Given this list of marker genes Eif4ebp1, Dixdc1, Pja2, Tmem255a, Baz2a, Hnrnpk, Lbr, Il17rd, Ankrd10, Trib2, Kdm7a (NCBI Gene Id 338523), Ttc23l, Ankrd17, Brinp2, Ppp4r3a, Arfgap3, Sar1a (NCBI Gene Id 67913), Elapor2, Krt26, Klhl24, Tmeff1, Enpp4, Ipmk (NCBI Gene Id 69718), Dyrk1a, 1700018B08Rik, Melk, Prr3, Setd1b (SET domain containing 1B), Agtr1b, Neurl1a, Klhl7, Kcnh8, Dera, Immt, Pcbp2, Sp4, Gask1a, Eea1, Ptgs2, Papss2, Vxn, Lrrc39, Rbpms, Ppp3r1, Arid2, Phf2, Uhrf2, Dner, Lemd3, Taf3, Hmgxb4, St3gal3, Alkbh7, Fam3c (NCBI Gene Id 27999), Ptprm, Mapkapk3, Eif5b, Brwd1, Ncoa1, Cnnm4, Zmynd8, Lmo4, Tbcel, Hnrnpc, Prss3b, Clk2, Nid2, Mdh1, Pdk1, Rbfox1, Ascl1, Mmgt1, Chd2, Cd163, Dll1, Tbc1d32, Zfp119b, Snx2, Sh3bgrl2, Tnfaip8l3 (NCBI Gene Id 244882), Zfp703, Fbxo11, Usp49, Cacna1g, Ddx3x, Kcnf1, Trpc5, Dnaja2, Mtdh, Chrna5, Nabp1, Slc30a8, Ermn, Pdzrn4, Znrf3, Wee2, Chic1, Ect2, Hycc2, Tcf24, Igfbp5, Cyp3a25, Eif4h, Tfcp2, Calcr, Lrba, Tmed5, Cntln, Tjp1, U2surp, Enc1, Luzp2, Zfta, Ccdc116, Appl1, Gm14295, Rtf1, Tm2d1, Lrp2bp, Prdx3, Nemp2, Adcyap1, Ulk1, Mfsd6, Ints6 (NCBI Gene Id 73038), Tmem167, Or2v1, Fam13c, Zbtb43, Slitrk1, Cacnb4, Smyd4, Nuak2 (NUAK family, SNF1-like kinase, 2), Nexmif, Mrc1, Ogt, Acsl4, Ces2e, Bicd1, Hdac1, Tmem200a, Rlim, Camk4, Dmc1, Cpne8, Vcan, Wapl, Satb2, Tnrc6b, Noc3l, Epha7, Rock1, Scoc, Ttc39b, Strip2, Crot, Ntf3, Bcar3, Usp21, Dlx1, Schip1, Zc3hav1l, Arhgef38, Hal, Kif26a, Cdk19, Selenot, Psd3, Tlcd4 (TLC domain containing 4), Spry4, Fars2, Elovl6, Gclc, Foxo1, Hoxd9, Ric1, Nsfl1c (NCBI Gene Id 386649), Bpnt2, Tcf7l2, Khdrbs3, Btrc, Sec23a, Sema5a, Ypel2, Zfp462, Rnf6 (ring finger protein (C3H2C3 type) 6), Klrb1b, Rbm12b1, Cdk2, Arl14epl, Usp10, Heatr3, Tab2, Klhl2, Zbtb6, Enpp1, Ei24 (NCBI Gene Id 13663), Tmem106b, Ppfia2, Ctbp1, Meis1, Fndc9 (fibronectin type III domain containing 9), Prelid3b, Btg1, Fem1c, Nadk, Scnn1g, Adamtsl1, Ttc39c, Sos1, Sh3kbp1 (SH3-domain kinase binding protein 1), Iqschfp, Abce1, Pcdh19, Nr0b1, Pdgfra, Ing3, Zdhhc3, Hoxa5, Gulp1, E2f5, Bicd2, Reep3, Ptx3, Celf1, Anks1b, Nfxl1, Morc3, Kcnd3, Focad, Nfib, Kif1b, Zfp871, Gfral, Snap25, Med26, Cebpg, Samd4, Frmd3, Zfp948, Spry2, Six4, Gm6377, Npy2r, Zfp950, Eml4, Tle3, Stim2, Mark2, Akr1b1, Arrdc3, Fnip2, Zfp442, Zfp607a, Tnfrsf19, Tsc22d2, Krt222, Ccdc65, Stk26, Armcx1 (armadillo repeat containing, X-linked 1), Zfp36l1, Gusb, Chn2, Dscam (DS cell adhesion molecule), Rab12 (RAB12, member RAS oncogene family), Metap1, Zzz3 (NCBI Gene Id 99926), Crebzf, Ttc9, Ctbp2, Sp9, Cetn1, Dppa4, Scai, Tmem196, Zfp704, Zyg11b, Fam217a, Ppp1r14c, Dkk2, Ppfibp1, Zfp157, Atxn1l, Tent5a, Cyp26b1, Usp25, Mob4, Afdn, Fut9, Irf2, Ppm1b, Lrch2 (leucine-rich repeats and calponin homology (CH) domain containing 2), Nol4, Atp6v0b, Gimap4, Zfp971, Oprl1, Ilf3, Mrtfb, Sertm1, Arhgap32, Tmem178, Map4, Rngtt, Tbpl1, Msi2, Mgat4a, Tial1, Ube2e3 (NCBI Gene Id 22193), Rasgrp3, Styx, Tcerg1l, Adcy2, Aak1, Svep1, Atl2, Mtcp1, Scaf11, Abhd17b (NCBI Gene Id 70566), Dusp10, Slc17a6, Tfap2a, Zfhx4, Ror2, Strbp, Aldh3a2, Gria4, Herc4, Setx, Nipsnap2, Ankib1, Prr16, Rnf2, Hspa5, Wdr33, Snx27, Dnm1l, Ptprz1, Prtg, Xiap, Nr2e1, Prps1, Agfg1, Nek7, Pira12, Pak6, Arhgap12, Atmin, Atp6ap1l, Lhx8, Ids, Fam120a, Lyplal1, H2-M10.6, Mfap3, Pdss1, Rab33b, Map2k3, Pabir2, Dennd6a, Ppp4r4, Zbtb44, Ikzf2, Jag1, Ttf1, Gata3, Stag1, Slc5a7, Suz12, Ppargc1a, Msl2, Stag2, Nhsl2, Fign, Yy2, Tspan7, Htr2c, Pphln1, Pcdhb17, Hdx, Prpf4b (pre-mRNA processing factor 4B), Drd1, Cdyl2, Zmat3, Fam53b, Kcnc2 (NCBI Gene Id 544750), Arhgap15, Gpalpp1, Slc22a3, Hmgn1, Arid4a (AT-rich interaction domain 4A), Pdcl2, Sox21, Cyb5r4, Lratd2, Togaram1, Sbsn, Fat4, Mesp1, Pcdh11x, Magel2, Vcpip1, Ttc21b, Pds5b, Uap1, Atp13a3, Zbtb41, Rif1, Sgip1, Rhoa, Rrn3, Rnf170, Cwc22, Rasgrp1, Hs3st5, Ipp, Lair1, Cxxc5, Clasp2, Gbp7, Rc3h1, Rsf1, Psd, Snap91, Hmgn5, Pknox1, Ddx42, Apol7a (apolipoprotein L 7a), Mtx3, Cacna2d1, Ltn1, Zcchc12, Bend4, Socs5, Rab3c, Epha5, Mob3c, Slc9a2, Lox, Lrrc58, Egr1, Rnf128, Gng7 (NCBI Gene Id 14708), Bcl2l11, Mtf2, Btc, Vstm2a, Barhl2, Nr1d2, Ankrd12, Bnc2, Cep20, Gbx2, Cpeb2 (cytoplasmic polyadenylation element binding protein 2), Aftph (aftiphilin), Il20rb, Hacd2, Hnrnpa3, Ncoa3, Prorsd1, Prep (NCBI Gene Id 28116), Slc39a9, Pum2, Snx25, Fmr1 (fragile X messenger ribonucleoprotein 1), Pogz, Nup58, Cxadr, Galntl6, Clec3a, Slc22a5, Myocd, Atp8a1, Per2, Kif2a, Fkbp6, Arid4b, Epcam, Otud1, Radx, Tmx4, Mab21l1, Rad21, Col5a2, Kbtbd7, Fry, Spred1, Bclaf3, Pitpna, Cdk17, Slc30a4 (solute carrier family 30 (zinc transporter), member 4), Pgr15l, Crbn, Slc8a1, Csnk1g3, Dnal1, Sav1, Bmt2, Kdm6a, Necab1, Snca (NCBI Gene Id 20617), Creb1, Zic3, Dmd, here is a description of the gene set: species: Mus musculus Genes predicted to be targets of miRBase v22 microRNA mmu_miR_350_3p in miRDB v6.0 with MirTarget v4 prediction scores > 80 (high confidence targets). Mouse Gene Set: MIR_350_3P from publication Chen Y, Wang X (PMID 31504780)